Given this list of marker genes MYD88, LCK, RAG2, DOCK8, CNBP (CCHC-type zinc finger nucleic acid binding protein), ICOS, ZBTB24, BLM, BTK, FNIP1, ARHGEF1, CD79B, EXTL3, POU2AF1, PTPRC, PLCG2, TNFRSF11A, MMEL1, AICDA, POLD1, IGKC, MOGS, IVNS1ABP, LIG1, TNFRSF13B, TCN2, IL6R, ORAI1, CD19, LRBA, KNSTRN, DOCK11, RFXAP, IL6ST, MST1, BACH2, IGHG2, IRF5, CBLB, CARD11 (NCBI Gene Id 84433), CR2, SPPL2A, IGLL1, TPP2, DNMT3B, PDCD1, PIK3CG, SH3KBP1, SEMA4D, STAT2, NFKBIA, LYN, CTLA4, POLE, PGM3, XIAP, STIM1, RAC2, TNFRSF13C, KLHDC8B, B2M, IKBKG, OTULIN, MAP3K14, RFX5, PIK3R1, TYMS, PRIM1, TCF4, SYK, POMP, UNG, PIK3CD, IL2RG, JAK3, SH2D1A, NAE1, TOM1, PTEN, RNF168, TNFSF15, TCF3, CASP10, CD40 (NCBI Gene Id 958), CD3E, NFKB2, GPR35, ALG12, FAS, LAMTOR2, VPS33A, POLD3, WAS, SPIB, ATP6AP1, FASLG, SASH3, SEC61A1, NSMCE3, TNPO3, PSMB10, PIGT, IL12RB1, RAG1, CASP8, ADA, RASGRP1, ADA2, CD247, CD40LG, SPI1, BLNK, IRF2BP2, IFNGR1, IL12A, SIK3, here is a description of the gene set: Abnormal circulating IgM concentration Human Gene Set: HP_ABNORMAL_CIRCULATING_IGM_CONCENTRATION An abnormal deviation from normal levels of IgM immunoglobulin in blood. species: Homo sapiens